The following is a description of a gene set: Genes down-regulated in lymph node T cells: wildtype versus EZH2 knockout. from publication Su IH, Dobenecker MW, Dickinson E, Oser M, Basavaraj A, Marqueron R, Viale A, Reinberg D, Wülfing C, Tarakhovsky A (PMID 15882624) Human Gene Set: GSE1566_WT_VS_EZH2_KO_LN_TCELL_DN studied in species Homo sapiens Lymph node T cells isolated from Ezh2fl/fl or Ezh2 deficient mice, and this is the list of marker genes: RMND1, ZSCAN12, SYTL3, SPPL3, PCDHB14, SUZ12P1, TMEM231, SOCS5, TBC1D24, POU2F2, ZNF148, RD3, ZCCHC14, PKDCC, USH1G, TRAV8-3, SPMIP8, SLC4A5, PSG3, SEC14L1, OLFML2B, ZNF841, ZNF396, SLC45A4, PARP4, PRKAG2, NUFIP2, RBM44, TAS2R46, SLC25A45, PPP1R13B, SIAH1, OR56B4, SLC44A3, RGL2, RAPGEF4, OR6M1, OR2A25, SEC22B, OR1L1, SLC39A1 (NCBI Gene Id 96436), TGFB3, SEMA6A, RAD54L2, TSPAN13, UPK3B, PECR, PCID2, PSME4, TBC1D4, TMEM72, ZBTB34, TMEM200A, RIF1, POP5, PIK3C3, ZNF341, ZNF672, TPPP2, YAP1, CCN5, SRSF11, ZNF91, SPATS1, TLE4, PTPRM, TLR5, OR12D2 (NCBI Gene Id 26529), PRPF8, PROX1, SLC10A6, SYNJ2BP, TAMM41, ZNF808, PFDN5, PDE2A, SEPTIN14, ZNF714, TMPRSS5, SLC35F2, RBP2, POU6F2, SNORD38A, SNORD42A, PHF8, TSEN2, SETD5, SNORA14B, ZNF530, RIBC1, ZEB2 (zinc finger E-box binding homeobox 2), SLC15A4, TCF12, UBE2I, SLC26A3, SNX19, PRSS30P, RAD51B, PNKP, ZNF781, ZRSR2P1, ZNF112, MAP3K19, GATD1, NTS, PLBD1, STK17A, PMAIP1, RP1, XRCC5, TMEM105, ZNF836, SNORD115-31, PPP1R13L, SLC9A4, RTF1, NTRK2, SLC25A3 (NCBI Gene Id 5250), PROCR, SPOCD1, USP42, STYXL1, NUP210, STAM2, PNLIPRP3, REG1A, NUMA1, VTI1A, NUP62CL, SPRYD7, RFX5, SLC5A7 (NCBI Gene Id 60482), PDE6D, OR4F15, SLC29A2, RNF7, SCUBE3, SPATA20, PLEKHM2, MRM3, SCARNA6, RBPMS, OPN5, ZNF879, SLC2A10, SLC37A3, RPL28, TAF1L, TRA2A, SFTPD, ZNF93, SLCO3A1, PRKCD, SMAD5, RIMS3, ZNF628, TGFB1I1, TMPRSS3, RSBN1, SLC17A6, XRN1, ZAR1L, ZNF592, SPDYE3, SCN7A, YIPF5, PGLYRP4 (NCBI Gene Id 57115), ZER1, ZNF484 (NCBI Gene Id 83744), TSPAN5 (NCBI Gene Id 10098), TMEM59L, RTTN, PTBP1, P2RX3, TMEM212, VWC2L, VANGL1 (NCBI Gene Id 81839), PTS, NSUN5, SERPINA6 (NCBI Gene Id 866), TAS2R60, OSTN, PPM1J, SNORD6, POLR2A, RHBDF2, PALB2 (partner and localizer of BRCA2), VPS33B, PDLIM3, SOX4, SNAI2, TRAF3, PBK, SH3BP4, OR10Q1, SQLE, YTHDC2, OR6C3